The following is a description of a gene set: studied in species Homo sapiens Catalysis of the transfer of a methyl group to a DNA molecule. Human Gene Set: GOMF_DNA_METHYLTRANSFERASE_ACTIVITY, and this is the list of marker genes: DNMT3A, DNMT1, MGMT, METTL4, N6AMT1, DNMT3B